Given this list of marker genes GREM2, RSPO2, ADAMTS6, NTN1, ZNF747, GALNT7, BLOC1S3, MBD1, SALL4, FAHD2B, RBL1, DCUN1D3, TMEM135, here is a description of the gene set: from publication Gao S, Yan L, Wang R, Li J, Yong J, Zhou X, Wei Y, Wu X, Wang X, Fan X, Yan J, Zhi X, Gao Y, Guo H, Jin X, Wang W, Mao Y, Wang F, Wen L, Fu W, Ge H, Qiao J, Tang F (PMID 29802404) species: Homo sapiens Human Gene Set: GAO_STOMACH_24W_C6_PIT_CELL